Given this list of marker genes E2F8, RRM2, DBF4, HMGB3, RRM1, RB1, STMN1, BUB1 (BUB1 mitotic checkpoint serine/threonine kinase), KIF2C, AURKB, CDKN2C, MKI67, SLBP (stem-loop histone mRNA binding protein), PRC1, DUT, PRIM1, LIG1, ANLN, CDCA7, RFC3, CCNE1 (cyclin E1), TOP2A (DNA topoisomerase II alpha), KPNA2, DCTPP1, ANXA8L1, CCNB2, RPA1, TK1 (NCBI Gene Id 7083), NSG1, HMGB2, FEN1, PCNA, NCAPH, SMC2, SGO1, LBR, CDT1, CDC20, EZH2, MCM3, CDK2, DNA2 (NCBI Gene Id 1763), NUSAP1, UBE2T (ubiquitin conjugating enzyme E2 T), PTTG1, CDK1 (NCBI Gene Id 983), RAD51, ASF1B (anti-silencing function 1B histone chaperone), TRIP13, KIFC1, CCNA2, MCM7, CCNB1, here is a description of the gene set: from publication Ishida S, Huang E, Zuzan H, Spang R, Leone G, West M, Nevins JR (PMID 11416145) Genes up-regulated in MEF cells (embryonic fibroblast) after expression of E2F1 or E2F2. species: Mus musculus Human Gene Set: ISHIDA_E2F_TARGETS We have used high-density DNA microarrays to provide an analysis of gene regulation during the mammalian cell cycle and the role of E2F in this process. Cell cycle analysis was facilitated by a combined examination of gene control in serum-stimulated fibroblasts and cells synchronized at G(1)/S by hydroxyurea block that were then released to proceed through the cell cycle. The latter approach (G(1)/S synchronization) is critical for rigorously maintaining cell synchrony for unambiguous analysis of gene regulation in later stages of the cell cycle. Analysis of these samples identified seven distinct clusters of genes that exhibit unique patterns of expression. Genes tend to cluster within these groups based on common function and the time during the cell cycle that the activity is required. Placed in this context, the analysis of genes induced by E2F proteins identified genes or expressed sequence tags not previously described as regulated by E2F proteins; surprisingly, many of these encode proteins known to function during mitosis. A comparison of the E2F-induced genes with the patterns of cell growth-regulated gene expression revealed that virtually all of the E2F-induced genes are found in only two of the cell cycle clusters; one group was regulated at G(1)/S, and the second group, which included the mitotic activities, was regulated at G(2). The activation of the G(2) genes suggests a broader role for E2F in the control of both DNA replication and mitotic activities.